Given this list of marker genes Fcgr3, Lgmn, Mpeg1, Tapbp, Clec4a4, Fcgr1, Ifi30, Fcer1g, H2-K1, Mfsd6, Clec4a3, Clec4a2, here is a description of the gene set: species: Mus musculus Mouse Gene Set: GOBP_ANTIGEN_PROCESSING_AND_PRESENTATION_OF_EXOGENOUS_PEPTIDE_ANTIGEN_VIA_MHC_CLASS_I The process in which an antigen-presenting cell expresses a peptide antigen of exogenous origin on its cell surface in association with an MHC class I protein complex. The peptide antigen is typically, but not always, processed from a whole protein. Class I here refers to classical class I molecules.